Given this list of marker genes Gbp2, Cfh, Gbp5, C9, C4b, Gm12250, Cfhr4, Gbp2b, C4a, here is a description of the gene set: Any constituent part of a secondary organism with which the first organism is interacting. Mouse Gene Set: GOCC_OTHER_ORGANISM_PART species: Mus musculus